The following is a description of a gene set: Genes predicted to be targets of miRBase v22 microRNA hsa-miR-6509-5p in miRDB v6.0 with MirTarget v4 prediction scores > 80 (high confidence targets). Human Gene Set: MIR6509_5P from publication Chen Y, Wang X (PMID 31504780) species: Homo sapiens, and this is the list of marker genes: TMEM14B, USP38, OTUD4, AQP11, WNK3, AIMP1, ZMYM1, NAALADL2, CDK5RAP1, FGF14, UBL3, SEC61A2, SYT10, SNX10, DHX35, RASGRP1, SUV39H2, ERAP1, PI15, DAB2, CREM, PNPT1, RANBP9, CD226, EHBP1, PCNP, RAB2A, HYCC2, MAP3K1, PDE10A, BCL7A, CELF2, AVIL, AKAP6, BHLHE41, RGS7BP, FCHO2, MYB, YBX1, PACRGL, N4BP2L1, NDNF, ATP13A3, OTC, TRMT1L, VNN1, GMNC, EFCAB7, TMEM14C, IGF2BP3 (insulin like growth factor 2 mRNA binding protein 3), SNAP91, LRRC58, PARP8, SEL1L, MAMDC2, EPC2, EDDM3B, RAB2B, HOXC8, ECT2, PRKG1, VWA8, FAM120B, SLC9A6, KRAS, SNCA, ERI2, GPR82, SIRT5, USP28, IRX3, ITGA9, NAIP, SIX1, MANEA, MYBL1, MPV17L, HERPUD2, DMAC1, CKAP2, KCNK2, PLA2R1, CEP350, ACYP2, CDH5, TAOK1, RNF138, NCOA2, ARSB, NUDT12, TTC14, CELF1, PPM1B, SNTN, ZRANB3